The following is a description of a gene set: studied in species Homo sapiens Multifocal cerebral white matter abnormalities Human Gene Set: HP_MULTIFOCAL_CEREBRAL_WHITE_MATTER_ABNORMALITIES, and this is the list of marker genes: RNASEH2B, RNU7-1, RNASEH2C, SLC25A15, RNASEH2A, D2HGDH, IFIH1, PUS3, ESAM, TREX1, SAMHD1, NOTCH3, GAA, TRAPPC9, ADAR, LSM11